Given this list of marker genes FOXC1, ABL1, YTHDF2, ITCH, PRKDC, METTL3, CDK6, HSPA9, OSM, SETD1A, N4BP2L2, EIF2AK2, KAT5, PUS7, NFE2L2, TMSB4X, TCF15, here is a description of the gene set: species: Homo sapiens Human Gene Set: GOBP_REGULATION_OF_HEMATOPOIETIC_STEM_CELL_DIFFERENTIATION Any process that modulates the frequency, rate or extent of hematopoietic stem cell differentiation.